Given this list of marker genes Mavs, Drd4, Rab36, Scg5 (NCBI Gene Id 98920), Vps16, Timm29, Ctsd, Grpel1, Cadps2, Snx25, Desi1, Cnr1, Mup4, Spg11, Dnajc14, Sys1, Zdhhc9, Tbc1d5, Stx17, Pde4c (NCBI Gene Id 270056), Irgm1, Siah3, Rftn1, F2rl2, Scrib, Shh, Bloc1s3, Ankle1, Sirt6, Hikeshi, Stx19, Lin7b, Slc9b2, Mia2, Ptpn14, Srprb, Nup214, Tmem97, Ei24, Aacs, Kcne1, Rab5c, Scamp2, Ubap1, Jak2, Gga3, Rab43 (RAB43, member RAS oncogene family), Tspan10, Npnt, Rab9b, Ykt6, Myt1, Vps11, Med1, Nucb1, Gas6, Atp5if1, Tmem167, Jup, Slu7, Egfr, Lin7c, Stim1, Ppm1f, Arl8b, Aip, Ppt1, Cln3, Cd3g, Dmbt1, Neurod1 (neurogenic differentiation 1), Oaz2 (NCBI Gene Id 18247), Tmem30a, Efna5 (NCBI Gene Id 13640), Park7, Rtp3, Mdm2, Steap3, Exoc7, Foxo1, Ano1, Nxt2, Clip3, Vamp5, Bcl3, Cog4, Abat, Trpc1, Ppp3cb (NCBI Gene Id 66215), Zdhhc7 (NCBI Gene Id 102193), Agk, Nup133, Uaca, Syngr2, Syvn1 (synovial apoptosis inhibitor 1, synoviolin), Pla2g6, Vps26c, Cltrn, 5730455P16Rik, Pink1, Zdhhc12, Klc1, Prkaca, Mcm3ap, Usp17le, Sec22b, Chmp7, Timm17a, Il10ra, Igtp, F2r, Mamdc4, Atp13a2, Itsn1 (intersectin 1 (SH3 domain protein 1A)), Arf4, Use1, Zdhhc6, Anp32b, Hmga1, Vps36, Tgfb3, Cep192, A1cf, Atg4d, Gopc, Il1rn, Camk2a, Slc1a1, Dgkd, Tmem126a, Psmd9, Camsap3, Elfn1, Grip2, Atp13a1, Nmu, Osbp, Rab3a, Erbin, Stxbp5l, Nxt1, Ift22 (NCBI Gene Id 67286), 1700009N14Rik, Zw10, Dnajc19, Ptpn22, Hps4, Lman1, Fgf9, Zc3h12a, Spcs1, Insig1, Prr5l, Fcgr4, Pom121, Cacna1c, Ptpn1, Tnpo3, Trim23, Srp19, Pdcd6, Myo5a, Ptgs2, Chmp1b (NCBI Gene Id 67064), Emc8, Snapin, Ube2g2, Fmn2, Golph3l, Fis1, Abca12, Hacl1, Pex14, Ipo11, Mttp, Kpna4, Xpo5, Vegfc, Cd24a, Gip, Kif17, Ankrd6, Agtr1a, Rep15, Rasl2-9, Stam2, Cntn2, Tomm40, Hook2, Cchcr1, Chrm1, Pikfyve, Xpo7, Snord35a, Cabp1, Snap25, Scamp3, Derl3, Dyrk1a, Commd1, Crhr2, Kdelr2, Cdkn1a, Gripap1, Acvr1c, Zfyve16, Nutf2-ps2, Ctdspl2, Washc1, Zfand2a, Arf1, Snx17, Rbsn, Arfrp1, Dynlt1b, Mtch1, Acsl4, Afdn, Akap1, Gabarapl2, Sgtb (small glutamine-rich tetratricopeptide repeat (TPR)-containing, beta), Il1b, Bbc3, Lyst, Snx16, Clta, Myo7a, Rab25, Pttg1ip2, Kdelr1, Zfand2b, Adar, Cox18, Klhl20, Smyd3, Stradb, Orai1, Isl1, Rab8b, Phb2, Ttn, Sacm1l, Rcn3, Tm9sf4, Elmod1, Clstn3, Lims1, Rbm4, Apba2, Fto, Ap5b1, Terf1, Rp2, Cct7, Cep135, Xpot, Atf2, Dgat1, Gpr27, Aqp11, Mpdz, Dusp18, Kcnb1, Lca5, Copa, Cope, Msr1, Ryr2, Snx27, Nup88, Vps45, Srp72, Mir200a, Malrd1, Anxa7, Chm, Atg10, Ptprn, Gphn, Rab5a, Sprn, Pcm1, Vps25, Sptbn1, Nup43, Mmgt1, Calcrl, Cog8, H1f5, Washc4, Tap2, Snx32, Pde8b, Vps29, Heatr5b, Appbp2, Tek, 2700049A03Rik, Pdzd7, Ywhag, Slc15a2, Nxf1, Gnptab, Ap2b1, Vti1b, Dlg4, Coro2b, Ift25, Duoxa2, Wipf1, Guk1, Fam3d, Pom121l2, Stx5a, Bard1, Dab2, Mon1a, Pdzk1, Adcyap1, Cep55, Pcsk1, Zdhhc4, Aaas, Ranbp17, Dennd10, Rab21 (NCBI Gene Id 216344), Rab27b, Abca1, Stx2, Jagn1 (jagunal homolog 1), Prickle1, Tnks, Filip1l, Plekhf2, Cct3, Snx7, Picalm, Slc12a2, Snap23, Prkn, Slc15a5, Tmco6, Gdi2, Elfn2, Phaf1, Bbs5, Eif3e, Pdcd5, Nup50l, Rab18, Mup1, Uevld, Prkar1a, Trak1, Trh, Vps53, Ap1s2 (adaptor-related protein complex 1, sigma 2 subunit), Gzmb, Dennd1a, Brca2, Kif14, Nsd2, Slc12a1, Gorasp1, Kpna2rt, Tcf7l2, Trip11, Asb3, Tomm5, Pik3r1, Gnai1, Ramp3, Calr, Trim28, Copb2, Cavin1, Sidt2, Glud1, Htt, Mapk8ip3, Astn2, Cep295, Piwil4, Frat1, Hsp90ab1, Eny2, Gsk3b, Prkce, Entr1, Parp11, Ncoa4, Plek, Dag1, Fchsd2, Trp53, Actn4, Sco1, Tmem258, Ptpn11, S100a13, Tiam1, Nrxn1, Wdr11, Comp, Micall1, Pmaip1, Dmap1, Rhbdd3, Pgap1, Sfrp1, B4galnt2, Pkdcc, Aktip, Get3, Rabep1, Atad1, Get4, Slc15a4, Arf2, Acsl3, Ins1, Lman2l, Tgfbrap1, Sergef, Rabgef1, Akap3, Rac1 (NCBI Gene Id 52352), Nup153, Cacna1e, Igf1, Kpna6, Trpm5, Zdhhc23, Cry2, Trpm2, Dynlt1c, Chga, Ccdc47, Ddx5, Reep2, Rab1a, Plk3, Slc10a7, Srebf1, Gbp2, Fndc1, Emc9, Rab12, Ffar1, Pmpcb, Glp1r, Moap1, Nutf2-ps1, Tmed1, Rpl11, Srcin1, Ift46, Pim3, Spcs2, Nr1h4, Selenok, Kcnj8, Cog6, Adipoq, Dop1a, Syndig1, Seh1l, Bsg, Pan3, Mcfd2, Nedd4, Exph5, Hinfp, Chmp4b, Akirin2, Cdkn2a, Tango6, Ptprn2, Nadk, Bbs1, Cnst, Cplane2, Cog1, Exoc6, Gfer (NCBI Gene Id 11692), Ppard, Emc1, Lsr, Dnajc15 (NCBI Gene Id 66148), Ahcyl1, Zdhhc17, Gli3, Trim37, Tspo, Ghrl, Rap1gds1, Kif20b, Gga2 (golgi associated, gamma adaptin ear containing, ARF binding protein 2), Srp14, M6pr (NCBI Gene Id 17113), Timm9, Exoc4, Pex10, Uts2, Ppp1r3c, P3h1, Rab6b, Ap2s1, Cplx3, Bbs2, Lrrk2, Cct4, Mon2, Arrdc2, Rab6a, Surf4, Chmp2b, Pick1, Chrd, Zdhhc24, Emc3, Vta1, Phldb2, Timm10b, Snx20, Ppid, Nlgn2 (NCBI Gene Id 216856), Wwp2, Eps15, Mcoln2, Wls, Sirt4, Psen2, Cltb, Nasp, Itpr1, Sirt7, Ubr5, Vps39 (NCBI Gene Id 269338), Myom1, Actr3, Bcs1l, Cd38 (NCBI Gene Id 12494), Apba3, Chp1, Mal, Hps6, Ap4s1, Yif1b, Mgarp, Zdhhc22, Ap3b2, Ap3m1, Clu, Tnpo1, Kcnq2, Prkcb, Bloc1s6, Fgg, Tgfb1, Bad, Raf1, Grb2, Snx9, Cacng3, Arfgef2, Afm, Hspb1, Arf5, Exoc2, Vps26b, Ppp3r1, Ap2m1, Emc2 (ER membrane protein complex subunit 2), Phip, Bax, Arl14, Stxbp5, Kif5c, Vps33b, Timm8a1, Gapvd1, Cela2a, Ergic3, Ccdc85c, Ccl5, Lonp2, Rala, Camk1, Ripor2, Tspan17, Tmed7, Gfap, Selenbp1, Sec61b, Tardbp, Cd200, Ube2j1, Vps13d, Grin3b, Mmp13, Tmed11 (transmembrane p24 trafficking protein 11), Fam3a, Golga4, Sec31b, E2f3, Ap1b1, Anxa1, Cacng2, Fam53c (family with sequence similarity 53, member C), Cib1, Spdya, Map4k4, Mapk14, Gosr1, Chmp4c, Vamp3, Kcnq3, Cct6a, Heatr3, Mvb12b, Carmil2, Immp1l, Ednra, Vldlr, Tmed10-ps, Myo1d, Tmed10, Hyal2, Nkx6-1, Traf3ip2, Phax, Rab5if, Sstr5, Slc30a8, Ptprv, Pitpnm1, Clock, Cbln4, Sox4, Agt, Gdi1, Apoc2l, Ywhae, Blk, Prepl, Faf2, Stx8, Snx15, Cpt1a, Nup93, Pot1b, Bcap31, Dynlt1a (NCBI Gene Id 100310872), Oprm1, Mtm1, Tunar, Epb41l1, Tomt, Nup188, Myo18a, Sorl1 (sortilin-related receptor, LDLR class A repeats-containing), Gja1, Snx8, Rab3c, Sort1, Apobec1, Hmgn3, Smo, Kpna1, Arhgef5, Arfgap1, Zfand1, Vps37c, Arl6, Mtnr1b, Zbed6, Oxa1l, Snord32a, Nedd1, Gpld1, Ank2, Oga, Cacna1d, Acvr2b, Tom1, Sec31a, Tbc1d17, Usp9x, Vps26a, Rest, Pfkl, Snx4, Sec61bl, Lmtk2, Erlec1, Ehd3, Ehd1, Birc5, Aspscr1, Rab17, Stxbp2, Flna (filamin, alpha), Il12b, Hcar2, Csk, Casp1, Chml, Timm8b, Tram2, Nup160, Rabif, Snf8, Svbp, Sdad1, Pex13, Trex1, Tm7sf3, Nrarp, Cubn, Mpc2, Epm2a, Dnajc1, Rab5b, Lamp1, Ramp2, Prpf4b, Gria2, Vamp2, Gpr89, Mcc, Pml, Ang5, Myh10, Madd, Rdx (radixin), Lhcgr, Pex26, Snap47, Snx33, Sec24a, Macf1, Rab33b (NCBI Gene Id 211346), Rapsn (NCBI Gene Id 19400), Dnm1l, Spag17, 4930550C14Rik, Trem2, Arfip2, Cdh1, Cdk5, Rab35, Prkaa1, Ap5z1, Slc7a6os, Srp9, Adcy8, Nploc4, Rabgap1l, Derl2, Parl, Six2, Vps8, Dnaja1, Bnip1, Adra2a, Praf2, Rph3al, Tbc1d1, Arfgap3, Rab29, Emc4, Golga2, Cep41, Syt7, Zfp827, Vps35, Cdk1, Exoc8, Zdhhc21 (zinc finger, DHHC domain containing 21), Foxa2, Rab32, Slc15a3, Ap3b1, Timm22, Senp2 (NCBI Gene Id 75826), Arrdc4, Apoc3, Kif5b, Mon1b, Hspa1l, Adam9, Casr, Pex2, Dlg2, Laptm5, Adam11, Alox5, Ptpmt1, Jakmip1, Grk3, Lrp5, Lrsam1, Rab8a, Optn, Snx19, Nsg1, Serp1, Mlph, Lepr, Maip1, Emc7, Ywhab, Arfip1, Ffar3, Sfn, Fuz, Ildr2, Plekha1, Rab28, Il6, Tmem132a, Idh2, Bbs7, Pex5, Ift56, Srp54a (NCBI Gene Id 24067), Bet1, Rhbdf1 (rhomboid 5 homolog 1), Atg4b, Bag6, Washc3, Arl6ip1, Tlk1, Becn1, Copb1, Snx24, Dtx3l, Rab31 (RAB31, member RAS oncogene family), Rab4b, Tmed5, Arl5b, Tcp1, Rab11fip1, Hspa5, App, Erc1, Chrm3, Ranbp6, Tom1l2, Napb, Wdpcp, Ramp1, Atg14, Mtx1, Syngr1, Hpca, Duoxa1, Arf3, Pik3c3, Zdhhc18, Sh3glb1, Snord34 (NCBI Gene Id 27210), Stx4a, Fam76b, Pmpca, C1qtnf3, Nup58, Bglap2, Bag3, Bbs4, Macroh2a2, Stx1a, Rbm22, H2-DMa, Vps50, Irgm2, Kcnj11, Tomm34, Six3, Kpna7, Tmco1, Elmod3, Uqcc2, Immp2l, Ruvbl2, Rffl, Nup62, Chmp6, Tomm6, Hspa9 (NCBI Gene Id 23909), Pik3r2, Timm8a2 (NCBI Gene Id 223262), Slc25a22, Ywhah, Cript, Zdhhc20, Rab3d, Chmp5, Kcnn4, Ap1m2, Amn, Rab22a, Rab39b, Neurl3, Rrbp1, Wnk1, Tent2, Ufm1, Hnf1b, Neurl1b, Chchd4, Cep290, P2rx7, Stx16, Coro1c, Tango2, Nipbl, Bag4, Prnp, Tomm20l, Golph3, Zdhhc11, Mtcl1, Ccdc91, Fam53b, Kif18a (NCBI Gene Id 99225), Syt4, Cetn3, Adora1, Ccdc22, Rabl3, Kcnip3, Cdc42, Rinl, Aagab, Arrdc1, Snx2, Appl1, Drd1, Scarb2, Chmp1a, Sft2d2, Rhbdd1, Timm23, Eipr1, Agrn, Plcb1, Ptpn5, Rab27a, Kcnj6, Pex1, Lamp5, Asb15, Mtnr1a, Colq, Ptpn23, Dennd2a, Ankrd10, Rcc2, Ap2a1, Adcy10, Snx30, Dnm2, Rab7, Sec23a, Rab26, Get1, Atg16l1, Arl5c, Ddit3, Tmem129, Pam16, Sar1b, Yod1, Prkcz, Wdr72, Vps4a, Arrb2, Necap1, Negr1, Pttg1ip, Rptor, Oaz3 (ornithine decarboxylase antizyme 3), Dnajc27, Lmna, Golga7b, Kpnb1, Herpud1, Pkd1, Ap2a2, Irs1 (insulin receptor substrate 1), Srp68 (NCBI Gene Id 70197), Lrwd1, Snx5, Apoc2, Nfkbia, Lyset, Ap1s1, Bmp4, Bcap29 (B cell receptor associated protein 29), Svip, Sec62, Steep1, Cartpt, Krt20, Folr2, Septin8, Pex16, Fbn1, Pex6, Vps52, Gnao1, Rab20, Nbea (neurobeachin), Abra, Abcc8, Cd74, Arl11, Cyp51, Pdcd6ip, Nolc1, Yipf5, Spire2, Sec61a2, Lyplal1, Mipep, Caml, Rims1, Tamalin, Neto1, Sirt3, Tert, Grpel2, Irs2, Stx1b, Mief1, Nup50, Unc119, Blzf1, Slc8b1, Map1a, Btf3, Pck2, Cog2, Fermt1, Tacr2, Kcnq1 (potassium voltage-gated channel, subfamily Q, member 1), Kif13a, Slc35d3, Pfkm, Apbb3, Erp29, Fgb, Myo1b, Rabl2, Synj2bp, Sytl5, Lmf1, C1qtnf5, Hook3, Romo1, Rab3b, Arfgap2, Nol3, Vps41, Hap1, Itga8, Hsp90b1, Lypla1, Os9, Vamp8 (vesicle-associated membrane protein 8), Cacnb1, Tom1l1, Hras, Acd (NCBI Gene Id 497652), Adtrp, Snx18, Arhgap33, Ppia, Zdhhc3, Akt1, Myo6, Trim50, Emd, Ndp, Oaz1, Cog5, Eif4enif1, Bet1l, Strada, Tesc, Nacad, Arcn1, C2cd2l, Nup85 (NCBI Gene Id 445007), Rims2, Rab11b, Ngfr, Kdelr3, Ifi27, Tvp23a, Nabp2, Tsg101, Mia3, Vps13c (vacuolar protein sorting 13C), Dop1b, Arl1, Sncg, Derl1, Ap4e1, Bcr, Coro7, Mief2, Rab3gap2, Cog7, Washc2, Rint1, Tnf, Comt, Rhbdf2, Plekhm1, Ap5m1, Atg4c, Ier3ip1, Ehbp1, Rilpl2, Arxes2, Hdac3, Nutf2, Cenpf, Egf, Ifng, Ahctf1, Hgs, Camk2n1, Lrrc8a, Pex3, Sorcs2, Snx12, Wdr83os, Atg7, Npff, Rab23, Src, Selenot, Zdhhc14, Rab11fip5, Abcg1, Kif3b, Rab3ip, Slc7a11, Hadh, Akap8, Mapk1, Ift27, Pola2, Mafa, Dmtn, Snx3, Mc4r, Exoc3, Bmpr1a, Asph, Vps37a, Kif20a, Sri, Tfrc, Nnat, Kpna3, Gdap1, Cetn2, Zmat3, Vti1a, Lrrc32, Rph3a, Cenpj, Cse1l, Cacnb3, Trpa1, Gcc2, Rab9, Tomm70a, Lamp3 (NCBI Gene Id 239739), Stxbp3, Gnaq, Ednrb, Mlc1, Camk4, Apba1, Tap1, Ndufaf2, Ripor1, Vps28, Vcp, Trim3, Snx21 (sorting nexin family member 21), Cd2ap, Sytl1, Scamp4, Drd2, Xpo4, Rab11fip3, Ush2a, Pex12, Cd36, Vgf, Ipo13, Ank3, Rab19, Sqstm1, Zdhhc25, Nr1h2, Spry2, Stx6, Ipo9, Tmed2, Abcb9, F2, Gpr68 (G protein-coupled receptor 68), Npc1, Sirt1, Apbb1, Cftr, Zfp384, Stk4, Macroh2a1, Arrdc5, Slc15a1, Vipas39, Nfatc3, Trmt10b, Naca, Cdk5r1, Hpse, Ap3s2, Gm14461, Golga7, Sucnr1, Ppm1a, Synrg, Rangap1, Akap4, Ap1g1, Hps1, Cct5, Cep120, Rab10, Reep1 (receptor accessory protein 1), Edn1, Ptp4a3, Doc2b, Plk1, Rab3gap1, Sec22a, Sec63, Prkd1, Nos3, Srp54c, Ffar2, Timm17b (NCBI Gene Id 21855), Nup54, Ist1, Fkbp1b, Rufy3, Crh, Fbxo7, Gck, Aup1, Rd3, Tmed4, Stxbp1, Bmpr2, Bmal1, Mff, Stat3, Fhip1b, Pdx1, Gper1, Peg12, Tcirg1, Ikzf1, Lman2, Hspa4, Ptbp1, Rapgef4 (Rap guanine nucleotide exchange factor (GEF) 4), Mvb12a, Nup107, Ttc8, Mdfic, Psen1, Stx11, Snx13, Trak2, Pex7, Stx18, Rab13, Nup35, Nup155, Stx7, Sft2d3, Ucp2, Il12a, Fam3b, Lin7a, Ube2q1, Tenm1, Rab3il1 (NCBI Gene Id 98136), Wrap53, Arl4d, Rfx3, Wbp2, Ankrd1, Sgta, Chp2 (NCBI Gene Id 70261), Emc6, Exoc5, Porcn, Nup62cl, Rab37 (NCBI Gene Id 58222), Stam, Txnip, Mir410, Sh3kbp1, Trarg1, Ogt, Sil1, Tuba1a, Vip, Apod, Vhl, Mtch2, Ndfip1, Ptger3, Gipr, Angpt1, Rab38, Itgam, Ep300, Cep131, Snap91, Arf6 (NCBI Gene Id 11845), Timm21, Nup37 (NCBI Gene Id 72714), Rtp2, Brca1, Gckr, Gpm6b, Baiap3, Mapt, Gnas, Dzip1 (NCBI Gene Id 67061), Copz2, Mtx2, Kif1a, Nomo1, Selenos, Ifnb1, Clstn1, Nup98, Bnip3l, Nagpa, Rab24, Il13, Pik3r4, Scfd1 (Sec1 family domain containing 1), Gabarap, Rilp, Cnih4, Zpr1, Dennd4c (NCBI Gene Id 99998), Zdhhc15, Rab1b, Psap, Agtr2, Ccn3, Ift20, Ghsr, Kif3a, Syt9, Agap3, Fam91a1 (NCBI Gene Id 52667), Ang2, B3gat3, Clip1, Unc13b, Anxa5, Mlxipl, Rhob, Lrp2, Tnfaip3, Sec23b, Nos1, Vamp4, Ctcfl, Syk, Golt1a, Hdac6, Pfkfb2, Arl4c, Epha5, Xpo1, Kif5a (kinesin family member 5A), Bid, Mfn2, Dynlt1f, Mup2, Cdk16, Myo1c, Umod, Washc5, Pak1, Cltc, Cemip, Ccdc93 (coiled-coil domain containing 93), Ranbp3l, Dusp21, Xpo6, Nr1h3, Tfap2b, Vmp1, Glul, Gpr119, Gorasp2, Exoc6b, Arl5a, Uso1, Txn1, Tgfb2, Pafah1b1, Rab2b, Mylk, Ncoa6, Hcfc1, Gprc6a, Lep (leptin), Gpihbp1, Tvp23b, Vps37b, Itgb1bp1, Pde1c, Epb41l5, Brsk2, Cd81, Zdhhc1, Agap1, Fras1, Rbp4, Dctn1, Elavl1, Pparg, Gga1, G6pc2, Selenbp2, Hk2, Rab7b (RAB7B, member RAS oncogene family), Ptger4, Rilpl1, Arrdc3, Frat2, Chmp3, Inhbb, Arrb1, Fyn, Mterf4, Ubl4a, Tomm7, Yif1a, Vps35l, Hnrnpm, Nos2, Ncf1, Klf7, Gja5, Snx11, Napg, Ndc1, Uty, Ccdc186, Rtn2, Bmp2, Il1a, Lamp2, Ppp3ca, Edem2, Arl8a, Ins2, Ang4, Aftph, Lrp1, Folr1, Scamp5, Golt1b, Pex5l, Sytl2 (synaptotagmin-like 2), Sel1l, Rpain (RPA interacting protein, NCBI Gene Id 69723), Ppp2r2b, Hook1, Pkia, Lcp1, Inpp5k, Srpra, Pdcd5-ps, Cfl1, Slc4a8, Tmem30b, Snx31, Uhmk1 (NCBI Gene Id 98572), Ucn3, Kpna2, Cct8, Rfx6, Dkc1, Nup210, Bbs9, Snx14, Hspd1, Fam53a, Tomm20, Chmp2a, Zdhhc19, Or51e2, Hnf1a, Nsf, Adcy5, Tmem9, Ktn1, Rack1, Cttn, Cask, Rab4a, Tram1l1, Hcls1, Vps4b, Ranbp2, Dennd1b, Slc16a1, Prf1 (perforin 1 (pore forming protein)), Ect2, Pard6a, Whrn, Unc119b, Gcg, Ice1, Ranbp3, Pkig, Snx6, Ap1s3, Large1, Vps37d, Rab11fip2, Gsdmd, Sec61a1, Apob, Tmem147, Timm44, Smad2, Cmtm6, Rab2a, Srp54b, Ap3s1 (NCBI Gene Id 11777), Ipo8, Dtnbp1, Tcaf1, Cenpe, Arl4a, Atg16l2 (autophagy related 16 like 2), Pard3, Rtp1, Sumo1, Vps54, Atg3, Copg1, Arl3, Sec16a, Arxes1, Ssr3, Cd68, Ing1, Per2, Aifm1, Tlr4, Tram1, Slc18a2, Grip1, Ufd1, Exoc1, Sytl3, Rtp4, Ndfip2, Ahi1, Tsc2, Gsk3a, Rhod, Fkrp, Gna11, Snap29, Ywhaz, Midn, Timm10 (NCBI Gene Id 30059), Macir, Gbp4, Mup11, Gbf1, Myh9 (NCBI Gene Id 97972), Drd3, F2rl1, Sar1a, Ap1m1, Vps33a, Erbb2, Nr1d1, Nectin3, Necap2, Cd63, Ipo5, Ang6, Dynll1, Ndel1, Ap3m2, Zfand6, Itgb1 (integrin beta 1 (fibronectin receptor beta)), Ipo4, Arl6ip5, Nr4a1, Pde3b, Adora2a (NCBI Gene Id 11540), Sytl4, Rufy1 (RUN and FYVE domain containing 1), Sec22c, Scamp1, Sybu, Atp2c1, Lsg1, Hif1a, Tomm22, Rabep2, Snord33, Oxct1, Ipo7, Cbl, Preb, Pgrmc1, Rap2a, Timm50, Arhgap1, Afg2b, Unc93b1, Stk3, Hnf4a, Chmp1b2, Nmd3, Emc10, Cbln1, Rab11a, Timm13, Sec61g, Copg2, Il33, Mapk10, Tlr2, Ywhaq, Syne3, Cog3, Vps18, Man1a, Frmd4a, Col1a1, Mup3, Gle1, Prkcq, Rapgef3 (Rap guanine nucleotide exchange factor (GEF) 3), Tecpr2, Fbxw7, Hsp90aa1, Ap4m1 (adaptor-related protein complex AP-4, mu 1), Napa, Trpm4, Capn10, Sec16b, Mmp12, Adgrv1 (NCBI Gene Id 432787), Spire1, Stx12, Sft2d1, Pclo, H13, B3glct, Ran, AU015836, Pcnt, Lrrc7, Mup5, Krt18, Hspa8, Tmed6, Arhgap44, Myo5b, Hk1, Ift122, Marcks, Gipc1, Tfr2, Rab34, C2cd5, Snx1, Spidr, Sec13, Pot1a, Rab15, Sp100, Tpr, Atg4a, Mcu, Braf, Atp6ap1, Stx3, Tbc1d13, Grin2a, Ccl2, Stom, Pdcd10, Efcab7, Ang, Dph3, Pcid2 (PCI domain containing 2), Frmpd1, Nf1, Bicd2, C1qtnf12, Idua, Gosr2, Samm50, Ap4b1, Prkcd, Smurf1, Rangrf, Ric1 (NCBI Gene Id 77643), Cadps, Nup42, Ncln, Vps51 (NCBI Gene Id 73190), Dnlz, Pex19, Ap3d1, Tnfrsf1a, Tmed9, Ap1g2, Akt2, Hmgcr, Cav1, Ooep, Ltbp1, Arfgef1 (NCBI Gene Id 226334), Myrip, Appl2, Tmed3, Fga, Rsad2, Notch1, Ap5s1, Neo1, Slc51b, Snupn, Spcs3, Hm629797, Sh3tc2, Apoe, Egr2, Arpc2, Olfm2, Xbp1 (NCBI Gene Id 52219), Cyb5r4, Zg16, Tnpo2, Mir130a, Edem1, Scfd2, Vps13a, Rab14, Copz1, Cct2, Ctns, Ndufa13, Slc2a2, Gnaz, Gbp5, Akap5, Snx10, Ubac2, Vsnl1, Ensa, Nlgn1, Zdhhc2, Gpr39, Cckar, Nr0b2 (NCBI Gene Id 23957), Ankrd27, Rab39, Zic1, Stxbp4, Cwh43, Tomm40l, Mir208b, Cplx1, here is a description of the gene set: The directed movement of a protein to a specific location. species: Mus musculus Mouse Gene Set: GOBP_ESTABLISHMENT_OF_PROTEIN_LOCALIZATION